The following is a description of a gene set: studied in species Homo sapiens Human Gene Set: WP_22Q112_COPY_NUMBER_VARIATION_SYNDROME 22q11.2 copy number variation syndrome, and this is the list of marker genes: TUBA3FP, USP41P, CLDN5, NKX2-5, MIR1306, RTN4R, PRKN, GP5, RORC (RAR related orphan receptor C), UFD1, CDH15, TBX1, DEPDC5, TNPO1 (NCBI Gene Id 3842), GNB1L, MRPL40, BCL2, GSC2, FOXC1, CBX5, HAND2, TSSK2, PRODH, DGCR5, P2RX6, GP1BB, NPRL3, RAN, PLK1, TXNRD2, LZTR1, RTL10, COMT, CHRD, NCOR1, ALDH1A2, DGCR2, H4C1 (NCBI Gene Id 8359), CYP26B1, KLHL22 (kelch like family member 22), DRD2, ESS2, THAP7, AIFM3, SHOC2, CRKL, FGFR2, KPNB1, GBX2, SNAP29, C22orf39, SREBF2, ACTC1, DROSHA, CCDC188, ALDH4A1, FGFR1 (NCBI Gene Id 84151), SREBF1, FAM230E (NCBI Gene Id 653184), SRF, TP53, PITX2, SLC2A4, LINC00896, SEPTIN5, MALT1, PPP1CB, MIR4761 (microRNA 4761), MIR6816 (NCBI Gene Id 102465490), FGF10 (NCBI Gene Id 2255), CLDN1, SNORA77B, CYP26C1, ZNF74, ZDHHC8, VWF, GP9, SHH, TANGO2, HIRIP3, CUL3 (cullin 3), GLUD1, RTN4, MED15, CLTCL1, HDAC3, HES1, SLC7A4, PAK4, RANBP1, SEPTIN8, FGF8, LRRC74B, SERPIND1, TMEM191A, CDC42, ACTA2, DGCR8, BMAL1, RANGAP1, MAG, FOXA2 (NCBI Gene Id 3170), ARVCF, SCARF2, DGCR6L, RELN, CYP26A1, NPRL2, XPO1, CLDN3, GP1BA, HIRA, TSKS, RBX1, DGCR11, EGFR, FOXC2, LINC01637, SLC25A1, PAX3, RCC1, ASF1A, PI4KA, TRMT2A, CDC45, EMC10, POLR2A, SEPTIN11, RAF1, OAT